Given this list of marker genes RNF111, POLE3, USP45, CUL4B (cullin 4B), DDB2, GTF2H4, MNAT1, COPS7B, ERCC1, RBX1, COPS7A, RFC4, RAD23B, SUMO1, PIAS1, GPS1, INO80, GTF2H5, DDB1, PARP2 (NCBI Gene Id 10038), RPA2, POLK, POLE4, RFC5, CCNH, GTF2H2, CDK7, COPS4, SUMO2, GTF2H3, POLE2, RPA3, COPS2, UBE2N, XPA, INO80B, XRCC1, POLD3, UBA52, PIAS3, RPA1, RUVBL1, ERCC5, XPC, RPS27A, CHD1L, COPS6, ERCC3, UBC, GTF2H1, POLE, POLD2, TFPT, ACTR5, MCRS1, LIG3, INO80D, POLD1, ERCC2, CUL4A, ACTL6A, COPS5, RFC2, COPS8, ACTR8, INO80C, PCNA, RFC1, CETN2, YY1, POLD4, UBB (ubiquitin B), RFC3, NFRKB, SUMO3, UBE2I, ERCC4, INO80E, RAD23A, LIG1, PARP1, COPS3, UBE2V2, ACTB, here is a description of the gene set: The DNA damage in GG-NER is recognized by the joint action of two protein complexes. The first complex is composed of XPC, RAD23A or RAD23B and CETN2. The second complex, known as the UV-DDB complex, is an ubiquitin ligase composed of DDB1, CUL4A or CUL4B, RBX1 and a GG-NER specific protein DDB2. In vitro, the UV-DDB complex is onlynecessary for GG-NER mediated repair of UV-induced pyrimidine dimers. In vivo, however, where DNA repair occurs in the chromatin context, the UV-DDB complex likely facilitates GG-NER mediated repair irrespective of the DNA damage type.<BR>After DNA damage recognition, the TFIIH complex, together with XPA, verifies the DNA damage and unwinds the DNA helix around the damage, creating an open bubble. Two DNA endonucleases, ERCC5 (XPG) and the complex of ERCC1 and ERCC4 (XPF), excise the oligonucleotide that contains damaged base(s) from the affected DNA strand. DNA polymerases delta, epsilon and/or kappa perform DNA repair synthesis, followed by DNA ligation, thus completing GG-NER.<BR>For a recent review, please refer to Marteijn et al. 2014. species: Homo sapiens Reactome Pathway: Global Genome Nucleotide Excision Repair (GG-NER) part of: Nucleotide Excision Repair